The following is a description of a gene set: species: Mus musculus Any process that modulates the frequency, rate or extent of viral life cycle. Mouse Gene Set: GOBP_REGULATION_OF_VIRAL_LIFE_CYCLE, and this is the list of marker genes: Oas1f, Lamp3, Oas1g, Tnf, Hacd3, Trim6, Kpna6, Adarb1, Ppihl, Nr5a2, Pde12, Oas3, Tasor, Mir378a, Ilf3, Plscr1, Zc3hav1 (zinc finger CCCH type, antiviral 1), Trim5, Kpna2, Mndal, Tmprss4, Trim25, Tarbp2, Mir24-1, Trim28, P4hb, Stau1, Ddx3x, Tmem39a, Znfx1, Hmga2, Rnasel, Nectin2, Aicda, Ccl5, Trim30c, N4bp1, Rsad2, Inpp5k, Ppih, Cd4, Oas1b, Vps37b, Ifi206, Ifi214, Ifi203-ps, Ark2n, Cd74, Trim15, Slpi, Vapb, Tsg101, Fmr1, Oas1h, Lgals1, Csnk2b, Larp1, Ifi203, Mphosph8, Oas1e, Shfl, Ch25h, Ifnb1, Apobec3, Cd209e, Bst2, Vps4a, Ifi208, Morc2b, Mir93, Oasl2, Trim11, Fam111a, Ifi207, Mavs, Ifnl3, Pkn2, Cd209c, Ddx5, Ifi213, Trim30b, Top2a, Srpk2, Morc2a, Ifitm1, Adar, Zfp809 (NCBI Gene Id 235047), Dicer1, Notch1, Hmgb1, Oasl1, Bcl2, Ifitm6, Top2b (NCBI Gene Id 319393), Ltf, Oas1d, Cnot7, Isg20, Furin, Ppia, Trim12a, Ppid, Srpk1, Ppie, Clec4g, Trim62, Banf1, Gbp7, D1Pas1, Ddb1, Hs3st5, Ifih1, Ifi209, Ifitm7, Tyro3, Mir24-2, Ifitm2, Oas1c, Axl, Setdb1, Mx2, Smpd1, Ifitm3, Cd209d, Trim12c, Oas2, Trim30d, Isg15, Trim30a, Fkbp6, Tmprss2, Prox1, Gm11772, Trim38, Oas1a, Eif2ak2, Bsg, Rad23a